The following is a description of a gene set: from publication Gavish A, Tyler M, Greenwald AC, Hoefflin R, Simkin D, Tschernichovsky R, Galili Darnell N, Somech E, Barbolin C, Antman T, Kovarsky D, Barrett T, Gonzalez Castro LN, Halder D, Chanoch-Myers R, Laffy J, Mints M, Wider A, Tal R, Spitzer A, Hara T, Raitses-Gurevich M, Stossel C, Golan T, Tirosh A, Suvà ML, Puram SV, Tirosh I (PMID 37258682) Human Gene Set: GAVISH_3CA_METAPROGRAM_MACROPHAGES_STRESS_HSP In this study, an extensive analysis was conducted to define meta-programs (MPs) capturing intra-tumor heterogeneity across a spectrum of tumor types. The approach utilized non-negative matrix factorization (NMF) to analyze each cell type separately within individual tumor samples. This involved the analysis of malignant cells, macrophages, fibroblasts, endothelial cells, epithelial cells, T-cells, and B-cells. NMF was executed with varying parameter values (K=4, 5, 6, 7, 8, 9), thereby generating 39 programs for each cell type per sample. Each NMF program was summarized by the top genes based on NMF coefficients.\nRobust MPs were then delineated for each cell type using a set of stringent criteria, including recurrence within the same tumor, similarity to programs in other tumors, and non-redundancy within a tumor. Subsequently, these robust NMF programs were clustered (per cell type) based on Jaccard similarity, leading to the identification of MPs associated with each cell type.\nTo enhance the quality of the MPs, a refinement steps were undertaken, involving the removal of MPs suspected of reflecting low-quality data (with an overrepresentation of ribosomal proteins or mitochondrial-encoded genes), single-study inclusion, or similarity to miss-annotated cell types. Genes upregulated in subsets of cells of a given type within various tumors species: Homo sapiens, and this is the list of marker genes: HSP90AA1, HSPA8, IER2, PMAIP1, FOS (Fos proto-oncogene, AP-1 transcription factor subunit), UBC (NCBI Gene Id 7316), RGS2, KLF4, HSPB1, CLK1, DNAJA4, BAG3, HSPA6, HSP90AB1, SGK1, DDIT4, TSC22D3, CXCR4, DUSP1, RGS1, DNAJA1, HSPD1, CCL4, ZFP36L2, IER5, NR4A2, KLF2, ATF3, FKBP4, EGR1, PPP1R15A, GADD45B, HSPH1, MALAT1, ZFP36, HSPE1, NR4A1, ZFAND2A (NCBI Gene Id 90637), HSPA1B, HSPA1A, JUNB, FOSB, KLF6, DNAJB1, JUN, CACYBP (NCBI Gene Id 27101), BTG2, RHOB (ras homolog family member B), CCL3, MAFB